Given this list of marker genes Nabp2, Pot1a, Hnrnpa2b1, Rad50, Rpa2, Stn1, Terf1, Terf2, Pot1b, Rpa1, Ctc1, Hsf1, Pcbp1, Terf2ip, Hnrnpa1, here is a description of the gene set: Binding to single-stranded DNA of a specific nucleotide composition. species: Mus musculus Mouse Gene Set: GOMF_SEQUENCE_SPECIFIC_SINGLE_STRANDED_DNA_BINDING